Given this list of marker genes Adcy6, Ephb2 (NCBI Gene Id 13844), Nectin3 (NCBI Gene Id 72384), Itgb1, Rab34, Cdk5 (cyclin dependent kinase 5), Nsg1, Tspan5, Kcnip3, Sorl1, Ppil2, Arl6, Pkp2, Vamp2, Csk, Wnk4, Sec13, Atp6ap1, Phaf1, Sesn2 (sestrin 2), Egfr, Zdhhc23 (NCBI Gene Id 385651, zinc finger, DHHC domain containing 23), Rap1a, Sfn, Lrrc7, Ehd3, Vamp8, Picalm, Cav3, Grip2, Stac2, Tspan14, Vti1b, Hectd1, Tmed2, Atp1b1, Ttc7b, Ccdc88a, Ypel4, Ldlrap1, Golga4, Gak, Zdhhc5, Rab26, Pkp1, Blzf1, Ank1, Nherf4, Acsl3, Prkcz, Inpp5k, Tspan33, Camk2a, Errfi1, Rhoq, Wdr24, Wdr59, Mrap, Csnk2a1, Rab10, Fcho2, Crb3, Washc1, Rilpl2, S100a10, Pip5k1a, Ttc8, Gas6, Vps35, Ppfia1, Bcl2l1, Gorasp2, F11r, Golph3, Atp2c1, Vamp4, Cdh1, Akt1, Arf6, Nrxn1, Nsf, Rab8a, Lyplal1, Arhgap44, Lypd1, Ptch1, Arhgef16, Cacnb3, Efr3b (NCBI Gene Id 668212), Rhbdf2, Myl12a, Skap1, Stac3, Amn, Vil1, Gpr158, Vps4a, Tmem150a, Dpp6, Anxa2, Lrp6, Bbs2, Ehd1, Ehd4, Myo5b, Atp1b3, Gpr179, Gper1, Grip1, Flna, Scp2, Cnpy4, Optn, Kif5b, Ar, Fyb2, Sys1, Rock2, Camk2g, Sptbn4, Commd1, Pgrmc1, Ank3, Vamp3, Scarb2, Ramp3, Macf1, Cltc, Rilpl1, Rapgef6, Cib1, Ikbkb, Prkg2, Tnik (TRAF2 and NCK interacting kinase), Csrp3, Trem2, Pik3r1, Epha3, Tm9sf5, Kif13a, Epb41l3, Stx3, Arl6ip5, Epha2, Sytl2, Pdzk1, Tgfb1, Dpp10, Kcnip4, Tpbg, Rer1, Nherf1, Rap2a, Myo5a, Actr3, Pkp3, Smurf1, Pdpk1, Ezr, Abca12, Rhog, Flot1, Rdx, Epm2a, Stx4a, Clip3 (CAP-GLY domain containing linker protein 3), Itga3, Fcer1g, Actb, Cln3, Nherf2, Rab13, Tmem59, Ramp1, Plekhf1, Wdr72, Fgf13, Fyb1, Sec23a, Gripap1, Jup, Bsg, Tnfrsf1a, Dennd4c, Akap5, Slmap, Cnst, Appl1, Bbs1, Tesc, Scn3b, Arfrp1, Stac, Rab11fip2, Slc4a1, Sec16a, C2cd5, Itgb1bp1, Tmem88, Pram1, Ramp2, Gga3, Cdh2, Vamp5, Rab31, Pigw, Stxbp1, Pals1, Rab7 (RAB7, member RAS oncogene family), Zdhhc2, Prph2, Mmp14, Prepl, Adipoq, Wnt3a, Hycc2, Palm, Numb, Pik3r2, Pkdcc, Map7, Agr2, Wnk3, Rab11fip3, Rangrf, Stx7, Lrrc15, Zfyve27, Nfasc, Pls1, Lgals3, Sqstm1, Rab11a, Rock1, Hycc1, Tmbim1, Rack1, Lama5, Mesd, Nhlrc1, Dlg1, Sorbs1, Kcnb2, Camk2d, Abi3, Ngdn, Ptpn9 (NCBI Gene Id 56294), Pacs1, Pacs2, Akt2, Dab2, Lrp1 (NCBI Gene Id 16971), Kcnj11, Exoc5 (NCBI Gene Id 218995, exocyst complex component 5), Rapgef2, Tescl, Pid1, Gga2, Golga7, Afdn, Wnk1, Ppp2r5a, Ins2, Tspan15, Sirt6, Kcnb1, Pgap2, Clasp2, Ttc7, Camk2b, Efr3a, Bag4, Trarg1, Dchs1, Ppp1r9b (NCBI Gene Id 217124), Lypla1, Rac1, Zdhhc4, Prkci, Krt18, Emp2, Sco1, Ap2m1, Golph3l, Scrib, Cd81, Zdhhc7, Nkd2, Actn2, Zdhhc22 (zinc finger, DHHC-type containing 22), Gorasp1, Cacnb2, Stx8, Atp2c2, Sptbn1, Zdhhc3, Large1, Tnf, Ehd2, Prnp, Snx27, Mrap2, P2ry1, Zdhhc25, Ift20, Atp2b4, Pacsin1, Frmd8, Cask, Ank2, Ins1, Flot2, Gga1, here is a description of the gene set: Mouse Gene Set: GOBP_PROTEIN_LOCALIZATION_TO_PLASMA_MEMBRANE A process in which a protein is transported to, or maintained in, a specific location in the plasma membrane. species: Mus musculus